The following is a description of a gene set: Reactome Pathway: Protein folding Due to the crowded envirnoment within the cell, many proteins must interact with molecular chaperones to attain their native conformation. Chaperones recognize and associate with proteins in their non-native state and facilitate their folding by stabilizing the conformation of productive folding intermediates. Chaperones that take part broadly in de novo protein folding, such as the Hsp70s and the chaperonins, facilitate the folding process through cycles of substrate binding and release regulated by their ATPase activity (see Young et al., 2004; Spiess et al., 2004; Bigotti and Clarke, 2008). part of: Metabolism of proteins studied in species Homo sapiens, and this is the list of marker genes: FBXO6, CCNE2, CCT8, GNG12, RGS11, TUBB1, FBXW4, CSNK2A1, HDAC3, GNGT1, TBCE, RGS7, ARFGEF2, DCAF7 (DDB1 and CUL4 associated factor 7), FBXL5, CCT3, CCT4, FKBP9, TCP1, GNB1, TP53, CSNK2B, KIFC3, GAPDHS, FBXW7, FBXW5, GNG4, PFDN6, GNG2, ARL2, SPHK1, TUBA4A, PFDN5, PFDN2, CCNE1, GNA15 (G protein subunit alpha 15), FBXO4, GNGT2, FBXW10, TUBB4A, GNG10, CCT2, PFDN4, TUBB4B, FBXW2 (F-box and WD repeat domain containing 2), RGS6, GNG8, TUBA3D, TUBB2A, CSNK2A2, GNB2, CCT6A, GNG13, GNG5, TUBA1B, TUBA4B, XRN2, ACTB, GNB3, STAT3, GNG3, TUBAL3, GNAQ, FBXL3, LONP2, TBCD, CCT7, AP3M1, TUBA3E, WRAP53, TBCC, CCT6B, RGS9, GNG7, TUBB6, PDCL, KIF13A, TUBA8, TUBB3, TUBA3C (tubulin alpha 3c), TUBA1C, FBXW9, VBP1, USP11, NOP56, GNB5, SKIC2, GNA11, GNA14, TBCB, GNG11, PFDN1, GNB4 (NCBI Gene Id 59345), GBA1, TUBB2B, TUBA1A, CCT5, TBCA